Given this list of marker genes Atp6v1b1, Tcirg1, Rnasek, Atp6v0e, Atp6v1c2, Atp6v0b, Atp6v0c, Atp6v0a4, Atp6v1f, Atp6ap1, Atp6v1a, Atp6ap1l, Atp6v0d1, Atp6ap2, Tmem199, Atp6v1g1, Atp6v1h, Atp6v1g3, Atp6v0a1, Atp6v1d, Ccdc115, Atp6v0a2, Atp6v1b2, Atp6v0d2, Spaar, Atp6v1e1, Atp6v1c1 (NCBI Gene Id 98003), Atp6v1g2, Atp6v0e2, here is a description of the gene set: Mouse Gene Set: GOCC_PROTON_TRANSPORTING_V_TYPE_ATPASE_COMPLEX A proton-transporting two-sector ATPase complex that couples ATP hydrolysis to the transport of protons across a concentration gradient. The resulting transmembrane electrochemical potential of H+ is used to drive a variety of (i) secondary active transport systems via H+-dependent symporters and antiporters and (ii) channel-mediated transport systems. The complex comprises a membrane sector (V0) that carries out proton transport and a cytoplasmic compartment sector (V1) that catalyzes ATP hydrolysis. V-type ATPases are found in the membranes of organelles such as vacuoles, endosomes, and lysosomes, and in the plasma membrane. studied in species Mus musculus